The following is a description of a gene set: Human Gene Set: GOBP_CEREBRAL_CORTEX_NEURON_DIFFERENTIATION studied in species Homo sapiens The process in which a relatively unspecialized cell acquires specialized features of a neuron residing in the cerebral cortex., and this is the list of marker genes: C21orf91, DRD1, LHX6, EOMES, NR2E1, ID4, RAC3, NKX2-1, ASCL1, TOX, HPRT1, ARX, SIN3A, ELAVL4, RAC1, CNTN2, OPHN1, PAFAH1B1, DRD2, HES1, PEX5, EMX1, CHD5, FEZF2, DLX1, DLX2, PSEN1, ZNF335 (NCBI Gene Id 63925)